Given this list of marker genes MIR520G, EIF2AK3, NODAL, GATA4, IL6, RORA, NDRG2, ADAMTS3, STAT3, MIR140, MIR134, C5, MIR132, MIR372, MIR302D, FLT4, ATF4, MIR378A, C3AR1, TGFB1, SARS1, TNF, MIR205, NOX1, MIR147A, IL1B, SULF1, MIR17, SULF2, HIF1A, IL6ST, MIR15B, MIR373, MIR20B, IL1A, BSG, MIR504, MIR195, MIR520H, MIR107, CCR2, PTGS2, MIR34A, ADORA2B (NCBI Gene Id 136), ISL1, IL6R, BRCA1, CYP1B1, ARNT, MIR874, HPSE, MIR15A, C5AR1, CXCL17 (NCBI Gene Id 284340), MIR361, MIR106A, CCBE1, C3, RELA, MIR16-1, MIR125A, MIR146A, MIR93, MIR20A, MIR199A1, here is a description of the gene set: The appearance of vascular endothelial growth factor production due to biosynthesis or secretion following a cellular stimulus, resulting in an increase in its intracellular or extracellular levels. Human Gene Set: GOBP_VASCULAR_ENDOTHELIAL_GROWTH_FACTOR_PRODUCTION species: Homo sapiens